Given this list of marker genes ATP7B, ERCC2, XPA, HBG1 (NCBI Gene Id 8047), MEFV, TRAPPC2, CCR1, CTLA4, AIP, MFN2, PTPN6, RNU4ATAC, ADA2, BUD23, MYH3, SFRP4, DDRGK1, IL2RB, HLA-DQA1, CHST3, GPR101, SMAD2, SLC26A2, CIITA, EPOR, COL1A1, FTL, PCSK9, AP1S3, ANKRD55, TRPS1, SLC40A1, GLA, LDLRAP1, KLRC4, SRSF2, LMNB2, ASXL1, SPP1, CR2, IL12B, IRF5, FAS, TET2, CLIP2, PSMB8, IL10, HLA-B, ERCC5, RUNX1, VCP, C1R, COPA, APC, CAV1, CLCNKB, IRF2BP2, CTNNB1, HLA-DRB1, ERCC4, NLRC4, SLCO2A1, CCN2, SEPTIN9, DDB2, P4HA2, HGD, COL5A2, ENPP1, MVK, HBB, COL6A1, COL11A2, LYN, IL6, LBR, IL23R, NOTCH2, HLA-DPB1, RFC2, NFKBIL1, IGKC, ASAH1, NOD2, IL36RN, MIF, GNPTG, HBG2, ANTXR2, ARSB, KLF1, SAT1, IRAK1, ABCG5, STX1A, PSTPIP1, MLX, SLC12A3, F8, PTPN22, MS4A1, UFSP2 (UFM1 specific peptidase 2), CCN6, BCL11A (NCBI Gene Id 55085), GTF2I, SLC22A4, PLCG2, COL9A1, STAT4, MSMO1, PSMB4, CD244, ERCC3, COMP, PHEX, C1QB, CD81, PLAAT3, DNAJC30 (DnaJ heat shock protein family (Hsp40) member C30), JAK2, LPIN2, ABCC6, KIF7, HPGD, FKBP6, XPC, NLRP12, TNFSF12, TNFRSF11B, TLR4, METTL27, C1S, TNFRSF13C, NFKB2, PKDCC, GNB2, LMNA, IGHG2 (NCBI Gene Id 3501), PIGT, HLA-DQB1, ANKH, HFE, LIMK1, PTPN2, CCR6, IL12A-AS1, ABCG8, GTF2IRD1, TMEM270, NFKB1, TREM2, IL2RA, HLA-DPA1, COL2A1, ICOS, NLRP3, TNXB, PTH1R, ELN, CHST11, ERAP1, CD55, BMP6, TNFRSF13B, ASPN, BAZ1B, C4A (complement C4A (Chido/Rodgers blood group)), MATN3, MAFB, COL5A1, MMP2, UBAC2, EIF4H, TNFRSF1A, PRTN3, LDLR, TLR7, COL10A1, POMP, VPS37D, DSE, COL11A1, TBL2, BMP4, IFNGR1, CBL, NCF1, IL1RN, SOST, TREX1, KIT, IRF4, LEMD3, IL12A, TYROBP, CD247, UBA1, SMPD1 (sphingomyelin phosphodiesterase 1), OTULIN, LACC1, CD19, APOB, STING1, GTF2IRD2, here is a description of the gene set: Arthralgia Joint pain. species: Homo sapiens Human Gene Set: HP_ARTHRALGIA